The following is a description of a gene set: Human Gene Set: chr1p22 studied in species Homo sapiens, and this is the list of marker genes: LINC01140, SNORA66, DNAI3, CCDC18, ZNF644, DIPK1A, CLCA1, LINC01763, RN7SL824P, RNU4-59P (RNA, U4 small nuclear 59, pseudogene), RNA5SP53, HMGB3P9, ENSG00000289881, PRKAR1AP1, MCOLN3, LPAR3, RPL36AP10, DNTTIP2, CCNJP2, TMED5, SNORD21, LRRC8D (leucine rich repeat containing 8 VRAC subunit D), RN7SL440P, CLCA4-AS1, MIR760, RPL7L1P22, ARHGAP29, GBP1, ELOCP19, MND1P1 (NCBI Gene Id 100127934), COL24A1, KYAT3, BCAR3-AS1 (BCAR3 antisense RNA 1), SYDE2, ACTBP12, SPATA1, MIR7856, GBP1P1, MTATP6P13, LRRC8B, SH3GLB1, RPL5, ABCA4, GBP5, RPL5P6, GBP2, MTCO1P21, CHCHD2P5, RNU6-970P, GAPDHP46, RPF1, GEMIN8P4, PHKA1P1, MCOLN2, RN7SL583P, ZNHIT6, CLCA3P, ENSG00000305783 (NCBI Gene Id 102724892), C1orf146, HSP90B3P, ENSG00000287797, ENSG00000284846, RN7SKP272, MTND4P11, EPHX4, GBP6, MTCO2P21, ODF2L, LINC02609, GBP7, FEN1P1, LPCAT2BP, LINC01555, CDCA4P2, ENSG00000288629, SNORD81, SNORD3G, C1orf52, LINC01364, MTCO3P21, RPAP2, PTGES3P1, CLCA2 (NCBI Gene Id 9635), BCAR3, BRDT, ARHGAP29-AS1, LRRC8C-DT, GFI1 (NCBI Gene Id 2672), ENSG00000286802, RN7SL653P, LMO4, LINC02801, SELENOF, RNA5SP52 (NCBI Gene Id 100873290), FNBP1L, LINC02787, PKN2-AS1, RNA5SP51, SSX2IP, MTF2, RN7SKP123, GBP4, PKN2, GCLM, RN7SL692P, LRRC8D-DT, LINC02788, HS2ST1, TGFBR3, RBMXL1, RPL17P5, EVI5, LRRC8C, RNU6-125P, LINC02795, SETSIP, GLMN, BTBD8, CDC7, BCL10-AS1, DDAH1, HFM1, GTF2B, H3P3, MTND3P21, RNU6-695P, CCDC18-AS1, GBP3, MIR4423, BCL10, CLCA4, BARHL2, GNG5, WDR82P2, CCN1 (NCBI Gene Id 3491), CAPNS1P1, CTBS, RPL36AP11, DR1, ZNF326, RNU6-210P